Given this list of marker genes B4galt5, B4galt1, St8sia2, Mgat2, St8sia3, B4galt4, Fuca1, Mgat4b, B4galt2, Fut8, St8sia6, Cga, Man2a2, B4galt3, Man2a1, Mgat4c, Mgat3 (NCBI Gene Id 68766), Mgat5, St6gal1, Mgat4a, B4galt6, St3gal4, Lhb, Chst8, Chst10, here is a description of the gene set: species: Mus musculus N-glycan antennae elongation in the medial/trans-Golgi Mouse Gene Set: REACTOME_N_GLYCAN_ANTENNAE_ELONGATION_IN_THE_MEDIAL_TRANS_GOLGI